The following is a description of a gene set: Mouse Gene Set: GOBP_NUCLEOBASE_CONTAINING_COMPOUND_CATABOLIC_PROCESS species: Mus musculus The chemical reactions and pathways resulting in the breakdown of nucleobases, nucleosides, nucleotides and nucleic acids., and this is the list of marker genes: Ppp2ca, Srsf1, Exosc4, Hsf1, Dnase1, Hdac4, Prkag2, Tent5d, Hprt1, Traf2, Elavl4, Tesk1, Csdc2, Cnot1, Nudt10, Dnase1l1, Ncbp2, Pnp2, Igf1, Rock1, E2f1, Nlrp5, Ep300, Exosc7, Enpp1, Exosc3, Zfp36l3, Traf5, Nudt8, Adpgk, Rnaseh2c, Rbm8a2, Cbfa2t3, Dxo, Tent2, Edc4, Mtch2, Nt5c1b, Mov10, Tymp, Brf1, Eno4, Fastkd3, Nudt19, Mlx, Slc4a1, Nnmt (nicotinamide N-methyltransferase), Igf2bp1, Dcp2, Zbtb20, Plekhn1, Hk1 (hexokinase 1), Slfn14, Jmjd8 (NCBI Gene Id 72106), Larp1, Trdmt1, Mtpap, Eno1, Exosc1 (exosome component 1), Ybx2, Rbm8a, Piwil4, Lsm1, Pfkfb3, Pkp3, Ago1, Ahcyl, Urad, Mettl1, Rgn, Dnase1l2, Nmnat1, Rbm46, Hspa1a, Exosc10, Thrap3, Cnot10, Ddit4, Tnrc6b, Hnrnpu, Gtpbp2, Aox1, Tardbp, Fam76b, Hnrnpr, Dnase2a, Pabpc4, Upf3a (NCBI Gene Id 75230), Prkag3, Exosc6, Pias4, Cnot9, Bpgm, Fitm2, Caprin1, Sgms1os1, Meioc, Alkbh5, Prr5l, Nudt16l2, Naf1, Eri1, Taf15, Rbm10, Rbm7, Mir196a-2, Fastk, Setmar, Parn (NCBI Gene Id 74108), Dnase2b, Dicer1, Zfp36, Slc4a4, Pnrc2, Alpi, Dctd, Mtor, Gpi1, Dpyd, Ythdf2, Xdh, Ddx5, Lipa, Tent4b, Slfn9, Psen1, Enpp4, Tirap, Magohb, Pop1, Blvra, Pfkp, Atm (ataxia telangiectasia mutated), Aldoc, Pcbp4, Zhx2, Rnaseh2a, Lsm4, Tnfrsf1b, Senp1, Cirbp, Pycr3 (NCBI Gene Id 67195), Hif1a, Fxr1, Rexo4, Nudt7, Ago3, Eno3, Cnot7, Mus81, Fbh1, Pde8a, Piwil1 (NCBI Gene Id 57749), Tkfc, Galt, Lrpprc, Mir7578, Zcchc7, Il3, Arid5a, Apaf1, Cnot3 (CCR4-NOT transcription complex, subunit 3), Nt5c2, Vps54, Gpd1, Slc29a1 (NCBI Gene Id 80657), Tbrg4, Nudt3, Exosc8, Nbas, Supv3l1, Exosc2, Pfkm, Ang4, Mir451b, Rnps1, Il17a, Smg1, Prkag1, Eif4enif1, Tnf, Hnrnpd, Ncf1 (neutrophil cytosolic factor 1), Hk2, Col6a1, Pfkfb1, Gdnf, Pklr, Slc11a1, Hk3, Nbdy, Trex2, Tut4, Prkaa1, Patl1, Lsm14b, Traf3ip2, Tnrc6a, Ogdh, Csde1, Ang, Hnrnpa0, Rnaset2b, Ncbp1, Rida, Vcp (valosin containing protein), Rock2, Fkrp (NCBI Gene Id 243853), Entpd1, Dhx9, Paip1, Entpd4, Exosc9, Dis3l2, Cnp, Mapkapk2, Gmpr2, Mlh1, Mex3d, Zar1, Pde7b, Cnot6, Upf1, Esrrb, Hbs1l, Mettl14, Prkaca, Src, Isg20, Gtpbp1, Sirt6, Fto, Piwil2, Hint1, Eif3e, Ppara, Dhx34, Tut7, Abcd1, Mlst8, Smg7, Pank4, Ins1, Aicda, Nt5m, Endog (NCBI Gene Id 13804), Cnot2, Vim, Acot2, Eloc, Gapdh (glyceraldehyde-3-phosphate dehydrogenase), Pgk2, Urah, Magoh, Ybx1, Noct, Pnpt1, Celf1, Galk1, Pgam1, Mpi, Smg9 (NCBI Gene Id 97419), Lsm2, Rbm47, Ago4, Btg2 (BTG anti-proliferation factor 2), Rbm24, Pde7a, Calcr, Dbr1, Gata5, Entpd8, Rnaset2a, Ythdf3, Aldob, Lin28b, Cpeb3, Itpa, Hnrnpc, Cacng7, Pan2, Pde8b, Gtsf1, Nupr1, Slirp, Skic3, Cnot8, Entpd7, Rptor, Cnot6l, Hkdc1, Eif4a3l2, Pgam2, Pelo, Cdadc1 (cytidine and dCMP deaminase domain containing 1, NCBI Gene Id 71891), Hspa1b, Nudt16, Smpdl3a, Ampd3, Nicol1, Wdr82, App, Foxl2, Dkc1, Smg5, Smg8, Mirlet7b, Actn3, Nudt5, Eno1b, Kat2b, Dcps, Zc3hav1, Fmr1, Slfn8, Casc3, Ago2, Flcn, Vip, Ern2, Pde12, Ptbp1, Phax, Uchl1, Tent4a, Zpr1, Git1, Mirlet7c-1 (microRNA let7c-1), Eno2, Nudt9, Adal, Bcl2l13, Slfn2, Hnrnpab, Insr, Pnp, Dera, Gale, Nsun4, Myd88, Myog, Prxl2c, Aifm1, Pde1a, Parp14, Dna2, Pum2, Mtrex, Exosc5, Stat3, Mir196b, Tent5c, Sidt2, Ncf2, Elavl1, Trim63, Sik2, Pcid2, Mir451a, Fastkd5, Etf1, Fastkd1, Enpp3 (ectonucleotide pyrophosphatase/phosphodiesterase 3), Fus, Ogt, Exog, Dut, Ada, Eif4a3l1, Nudt11, Fen1, Secisbp2, Trex1, Nanos1, Cdkn2a, Pde4a, Apex1, Rbm33, Tut1, Aldoa, Cda, Tob1, Zc3h4, Dnd1, Igfbp3, Dis3, Nudt17, Trir, Fbp1, Samd4b, Ifng, Zswim8, Mettl16, P2rx7, Lsm6, Gapdhrt2, Pde2a, Upf2, Khk, Nt5c3, Prkaa2, Uox, Qki, Nudt12, Patl2, Polr2g, Xrn2, Rnaseh1, Samhd1, Larp4b, Ctif (CBP80/20-dependent translation initiation factor), Dnph1, Axin2, Arnt, Dctpp1, Khsrp, Nudt16l1, Tigar, Nt5c1a, Hnf4aos, Rbm38, Entpd3, Angel2, Npm1, Mrto4, Nudt13, Ucp2, Rc3h1, Zc3h12d (NCBI Gene Id 237256), Ssb, Boll (boule homolog, RNA binding protein), Mir144, Eif4a3, Pan3, Vnn1, Gspt2, Igf2bp2, Ythdf1, Vegfa, Cant1, Tent5b, Zc3h14, Zcchc17, Xrn1, Nt5c, Scgb1a1, Dcp1b, Carhsp1, Nudt1 (nudix hydrolase 1), Rnaseh2b, Acat1, Rc3h2, Dnase1l3, Zc3h18, Arl2, Pde9a, Snd1, Dhx36, Nt5e, Smg6, Syncrip, Pfkl, Mir466l, Cidea, Dffb, Dhtkd1, Lsm7, Tpi1 (triosephosphate isomerase 1), Samd4, Nudt4, Entpd2, Aldoart1, Nudt15, Art2a, Gas5, Elob, Lsm5, Tnrc6c, Pde4d, Entpd5, Gck, Skic2, Upp2, Mlycd, Gapdhrt, Entpd4b, Skic8, Fastkd2, Il6 (interleukin 6), Upp1, Slc2a6, Gapdhs, Enpp5, Apobec1, Pde4c, Nudt18, Mlxipl, Nanos3, Zbtb7a, Pgk1, Dazl, Nanos2, Upf3b (UPF3 regulator of nonsense transcripts homolog B (yeast)), Pkp1, Oas2, Lin28a, Pkm, Gigyf2, Mettl3, Dis3l, Ttc5, Pnrc1, Ahcy, Dpys, Dffa, Zfp36l2, Pym1, Mfsd8, Upb1 (NCBI Gene Id 103149), Pde5a, Ncor1, Edc3, Mirlet7c-2, Eif6, Aldoart2, Zfp36l1, Fhit, Pum1 (NCBI Gene Id 80912), Ppargc1a, Mir196a-1, Ikbke (NCBI Gene Id 98726), Igf2bp3, Pnldc1, Foxk2, Pde10a, Trnt1, Bax, Pabpc1, Acot7 (NCBI Gene Id 70025), Trim71, Pfkfb2, Ier3, Pabpn1l, A1cf, Mgat1, Grsf1, Gda, Myc, Fxr2, Htr2a, Nsun2, Dcp1a, Zc3h12a (NCBI Gene Id 230738), Ddx49, Tent5a, Gspt1, Sarm1, Foxk1 (NCBI Gene Id 17425), Nrde2, Rnasel, Ins2, Art2b